Given this list of marker genes Asph, Mef2c, Prrx1, Ppp1r3a, Rb1cc1, Btbd3, here is a description of the gene set: Mouse Gene Set: IKEDA_MIR133_TARGETS_DN Calcium signaling is a central regulator of cardiomyocyte growth and function. Calmodulin is a critical mediator of calcium signals. Because the amount of calmodulin within cardiomyocytes is limiting, the precise control of calmodulin expression is important for the regulation of calcium signaling. In this study, we show for the first time that calmodulin levels are regulated posttranscriptionally in heart failure. The cardiomyocyte-restricted microRNA miR-1 inhibited the translation of calmodulin-encoding mRNAs via highly conserved target sites within their 3' untranslated regions. In keeping with its effect on calmodulin expression, miR-1 downregulated calcium-calmodulin signaling through calcineurin to NFAT. miR-1 also negatively regulated the expression of Mef2a and Gata4, key transcription factors that mediate calcium-dependent changes in gene expression. Consistent with the downregulation of these hypertrophy-associated genes, miR-1 attenuated cardiomyocyte hypertrophy in cultured neonatal rat cardiomyocytes and in the intact adult heart. Our data indicate that miR-1 regulates cardiomyocyte growth responses by negatively regulating the calcium signaling components calmodulin, Mef2a, and Gata4. Genes down-regulated in hypertrophic hearts (due to expression of constitutively active form of PPP3CA) and predicted to be targets of miR-133 microRNA. from publication Ikeda S, He A, Kong SW, Lu J, Bejar R, Bodyak N, Lee KH, Ma Q, Kang PM, Golub TR, Pu WT (PMID 19188439) species: Mus musculus